The following is a description of a gene set: Genes up-regulated in comparison of naive CD8 T cells from ELF4 defficient mice versus activated CD8 T cells from ELF4 defficient animals. Transcription factors that regulate quiescence, proliferation, and homing of lymphocytes are critical for effective immune system function. In the present study, we demonstrated that the transcription factor ELF4 directly activates the tumor suppressor KLF4 downstream of T cell receptor (TCR) signaling to induce cell cycle arrest in naive CD8+ T cells. Elf4- and Klf4-deficient mice accumulated CD8+CD44hi T cells during steady-state conditions and generated more memory T cells after immunization. The homeostatic expansion of CD8+CD44hi T cells in Elf4-null mice resulted in a redistribution of cells to non-lymphoid tissue due to reduced expression of the transcription factor KLF2, and the surface proteins CCR7 and CD62L. This work describes the combinatorial role of lymphocyte-intrinsic factors in the control of T cell homeostasis, activation and homing. from publication Yamada T, Park CS, Mamonkin M, Lacorazza HD (PMID 19412182) Human Gene Set: GSE15324_NAIVE_VS_ACTIVATED_ELF4_KO_CD8_TCELL_UP studied in species Homo sapiens, and this is the list of marker genes: SIPA1L2, NR1D1, RAB1B, B4GALT7, MLX, SH3PXD2A, BCO2, SRD5A3, PLEKHG5, TRAPPC2L, SPEM1, HAND2, SLC39A3 (NCBI Gene Id 92729), ADAM12, TSACC, IL6ST, MAP3K2, ZNFX1, MED11, NMB, AJAP1, NUDT6, CHPT1 (NCBI Gene Id 56994), CIAO2B, SLC10A3, USP21, SAA1, HDAC11, PRMT9, PLEKHA1, SLC25A45, FEM1A, QPCT, RALGDS, WWP2, ETHE1, MAP3K14, KREMEN1, NARF, TMEM80, DPYSL4, PTPN12, VPS9D1, IP6K1, HAGHL, METTL3, TOR2A (NCBI Gene Id 84633), ABCC8, HR, WNT5B, OSBP2, FBF1, C19orf67 (NCBI Gene Id 648272), C9, EVI2A, BTAF1, PSMB10, TREML2, MRNIP, PRRT3, MAN2B2, RAPGEF2, WIPI1, DUSP1, BCDIN3D, SOCS1 (NCBI Gene Id 8651), SLC26A11, ZCCHC12, CD14, FAM117A, FAM210B, NHSL2, KMT2D, VOPP1, USP2, TNIK, MAP3K9, FAM98C, NSRP1, BCL2L11, DMAP1, C19orf53, HPCAL1, CACNA2D4, AGTRAP, MEGF11, RXRG, DOCK8, PSMG4, STMN3, SLC6A19, TRIM26, AP3M2, ELAC1, PHF14, TEX264, SOX5, EFEMP2, MTMR10, PNPLA7, MAP3K11, TPGS1, PPP4R3A, TMC1, OMD, USP28, ASPSCR1, ACOT8, PHKG2, SKI, MPHOSPH9 (M-phase phosphoprotein 9), ELMOD3, VIPAS39, MYL11, GTPBP1, KLHDC3 (NCBI Gene Id 116138), GLMP, BACE1, PLCB2, MEIS3, WFDC1, TEN1, FSD2 (NCBI Gene Id 170466), RELT, TCF4, PEX10, CRYBB1, SNX30, ATP5MG, KAZALD1, DCTN1, CHAD, LETM2, ELMO3, RIGI, OSER1, NPC1, TF, CLASRP, NECAP2, LPAR6, ABHD10, CNTRL, NDUFA6, CIZ1, FRMD4A, MRPS11, HAAO, PTPN18, PDLIM5, CLTB, PIGP, ZBTB2, POU2F3, PTK7, DCAF4, TTN, IMPDH2, RAB11FIP4, DIRAS1, FMC1 (formation of mitochondrial complex V assembly factor 1 homolog, NCBI Gene Id 154791), NT5E, RBM42, SMAD3, EMX2OS, LRRC1, TMEM81, SIAH1, APBB3, TSHZ1, ABCA7, SYT2, MCEE, COX20, FUOM (fucose mutarotase), ZFP3, ZFAND3, GPANK1, MECP2, TBC1D9B, ANKMY2, ITPR3, CREBBP, UCKL1, MEPCE, TBL1X, CLCN4, IFIT2, EPHB6, SPIC, CELA3B, HEXIM1 (NCBI Gene Id 10614), SAFB, GBF1, PTCHD1, PDLIM7, GPR180, MIIP, RFXANK, EIF3K